Given this list of marker genes Pin1, Sh3glb1, Krt17, Bdnf, Mir467a-9, Golga4, Klhl22, Derl2, Mir467a-5, Eif4g2, Csnk2a1, Apoe, Adrb1, Exosc9, Smurf1, Syt4, Exosc2, Avpr1a, Ncoa3, Bcl11a, Sfn (NCBI Gene Id 55948), Mir21a, Map3k13, Mir467a-3, Nedd4l (NCBI Gene Id 83814), Twf2, Cyfip1, Picalm, Mtor, Mir467a-7, Macf1, Rnd2, Ndel1, Mlst8, Ntn1, Adnp, Cpne6, Lrp1, Rufy3, Fn1 (NCBI Gene Id 269206), Prkn, Adcy10 (adenylate cyclase 10), Ptk2, Syt17, Kdm2b, Cep43 (NCBI Gene Id 75296), Afdn, Syt1, Tnfrsf12a, Eif4g1, Cdkn2aip, Mapt, Pabir1, Vegfa, Trip10, Slc25a33, Dbn1, Ucn, Cdh4, Il9r, Map1b, Ep300, Ddx39b, Zfp639, Dnph1, Erbb2, Mfsd2a, Mir467a-1, Ncbp1, Rictor, Cxcr4, Lpar3, Megf8, Igfbp1, H3f5 (NCBI Gene Id 667250), Gsk3b, Flt4, Mir467a-2, Cpne5, Wnt3a (NCBI Gene Id 22416), Hyal1, Adam17, Cfl1, Sdcbp, Ptk2b, Map2k5, Rasal1, Hdgfl2, Cxcl16, Ngf, Uts2r, Trpc5, Tead1, Egfr, Myo5b, Pin1rt1, Shtn1, Rims1, Sirt1, Cxcl12, Mmp14, Crabp2, Cyba, Ino80, Mir467a-10, Disc1, Ddx49, Trim32, Unc13a, Lgi1, Brat1, Syt3, F2, Dbnl, Bcl2 (NCBI Gene Id 98734), Eif2b2, Wnt3, Edn1, Rnf157, Mir155, Extl3, Nr3c1, Mapkap1, Prr5, Tgfb2, Rptor, Slc23a2, Cib1, Ccn4, Cdc42, Islr2, Pak1 (p21 (RAC1) activated kinase 1), Gdi1, Akap6, Fxn, Dcx, Fdps, Limk1, Crk, Sema7a, Cdkl5, N6amt1, Mir467a-8, Mir467a-6, Ddx3x, Hnrnpk, Cacng7, Tgfbr1, Exosc4, Nrg1, Il9, Acsl4, Efna5, Supv3l1, Rpl4, Smad7, Nrp1, Igf1, L1cam (L1 cell adhesion molecule), Hamp2, Slc9a1, Cryaa, Mtpn, Sgk1, Itsn2, Yap1, Ntrk3, Sphk1, Hpn, Cntf, Ist1, Rhoa (NCBI Gene Id 51787), Psmd10, Mul1, Usp47, Wnt5a, Ilk, Sema4d, Hbegf, Sfrp1, Syt2, Cpne9, Trpv2 (NCBI Gene Id 22368), Slc25a4, Slc44a4, Pou4f2, Avp, Pum2, Dscam (NCBI Gene Id 78761), Arhgap32, Plaa, Sema5a, Akt1, Anapc2, Sfrp2, Pafah1b1, Bmpr2, Mir467a-4, Parp2 (NCBI Gene Id 30876), D1Pas1, Cd38, Adam10, Zfyve27, Mecp2, Srf, Taf9b, Hamp, Commd5, Reg1, Armc12, Rims2, here is a description of the gene set: Mouse Gene Set: GOBP_POSITIVE_REGULATION_OF_CELL_GROWTH Any process that activates or increases the frequency, rate, extent or direction of cell growth. species: Mus musculus